Given this list of marker genes ZNF687, PCLAF, ILF3-DT, FANCD2, KBTBD6, GSPT1, DMD, NELL2 (NCBI Gene Id 4753), RRM2, GAPDH, PPM1D, DNAJC5G, PHF5A, SASS6, YTHDC1, CDCA7, ASXL2, FANCG, ADAMTS2, APPL1, RBL1, TBX6, POLR2A, CASP8AP2, E2F1, CDC6, PRKDC, TMEM187, EED, GINS3, KBTBD7, BRPF1, TLE3, RPS20, H2BC12, EPHB1, ZNF503, JADE1 (jade family PHD finger 1), POLD3, ZIM2, SEMA6A, SLC9A5, HMGXB4, PIM1, TRMT6, TRMT2A, PLAGL1, MSH5, TOPBP1, E2F8, MCM4, MRPL40 (mitochondrial ribosomal protein L40), PODN, CDK1, RASAL2, POLA1, NOLC1, MYC, CLSPN, TMPO, RMI2, SLCO3A1, MCM7, CORT, JADE2, KANSL3, PHC1, POLE2, NIPBL, HIRA, HMGA1, RTBDN, PRP4K, STMN1, IPO7, SYNCRIP, KIAA0825, WBP2NL, PBRM1, ATAD2, E2F7, PCNA, SOAT1, NCL (nucleolin), IER5L (NCBI Gene Id 445576), TRIM39, AP4M1, DCK, RAVER1, SRSF7, HNRNPUL1, SP3, GPBP1, FBXO5, UNG, NFATC2IP, SMC1A, WDR62, ATAD5, USP37, ZCWPW1, H2AZ1, ACBD6, VCAN, SNRPD1, DCTPP1, ARID4A, TMEM108, ZBTB4, ILF3, HNRNPR, EZH2, STK35, STT3B, SPTB, KCNA6, PKMYT1, SYNGR4, SPINK5, STAG2, ID3, PAQR4, DNMT1, PRPS1, MCM8, GON7, MCM2, EIF4A1, PPIG, MCMBP, NUP62, SUMO1, TYRO3, TMEM143, ZNF565, HS6ST3, POLD1, MCM6, H4C1, GMNN, E2F3, GABRB3, TRMT13, NR6A1, PCIF1, NUFIP2 (nuclear FMR1 interacting protein 2), NASP, GLRA3, HNRNPA2B1, CCNT1, AK2, FKBP5, APH1A, CDC20B, CDC25A, FIZ1, CDC5L, NRK, H2AC12 (H2A clustered histone 12), CTDSPL2, GPRC5B, POU4F1, GRIA4, AP1S1, SUV39H1, EMSY, GEN1, CBX3, BRME1, GATA1, TFAP4, IL4I1, UBR7, PEG3, FMO4, PTMA, ZNF524, OTUD7B, KMT5A, ATF5, LUC7L3, PAN2, ING3, SMC6, MCM3, PRPS2, FANCC, ARHGAP11A, TRA2B, MEPCE, BRMS1L, PAX6, YBX2, MAZ, ZNF367, CAND1, SRSF1, HNRNPD, POLE4, RPS6KA5, PCSK1, UGGT1, RIBC1, H3C1, EFNA5, MSH2, ZCCHC8, ARHGAP6, KCNS2, MAP3K7, MYH10, EHBP1, SLC9A7, NABP2, MAPK6, HCN3, RANBP1, SMAD6, ACO2, DLG3 (NCBI Gene Id 89363), ZNF644, DNAJC9, H2AZ2, SMC3, FHOD1, STAG1, RET, TAOK2, MAPT, MXD3, MTF2, THAP8, ALDH6A1, POLR1G, ZNF362, HOXC10, CNOT9, EMC3, here is a description of the gene set: Genes having at least one occurrence of the motif TTTSGCGC in the regions spanning 4 kb centered on their transcription starting sites. This matches the transcription factor binding site V$E2F_02 (v7.4 TRANSFAC). Human Gene Set: E2F_02 studied in species Homo sapiens